The following is a description of a gene set: part of: HIV Life Cycle The late phase of the HIV-1 life cycle includes the regulated expression of the HIV gene products and the assembly of viral particles. HIV-1 gene expression is regulated by both cellular and viral proteins. Although the initial activation of the HIV-1 transcription is facilitated by cellular transcription factors including NF-kappa B, this activation results in the production of primarily short transcripts. Expression of high levels of the full length HIV-1 transcript requires the function of the HIV-1 Tat protein which promotes elongation of the HIV-1 transcript. The HIV-1 Rev protein is required post-transcriptionally for the expression of the late genes. Rev functions by promoting the nuclear export of unspliced and partially spliced transcripts that encode the major structural proteins Gag, Pol and Env, and the majority of the accessory proteins (Malim et al., 1989; reviewed in Pollard and Malim 1998. Reactome Pathway: Late Phase of HIV Life Cycle species: Homo sapiens, and this is the list of marker genes: GTF2E2, NUP98, AAAS, GTF2H4, XPO1, CHMP4A, vpr, POM121, UBC (ubiquitin C), UBA52, GTF2F2, TCEA1, CCNK, CHMP2B, UBAP1, TAF6, MVB12A, TAF15, vpu, POLR2J (NCBI Gene Id 5439), CHMP4C, RAE1, TAF10, POLR2A, VPS37B, RPS27A, ERCC3, TAF4B, TAF1L, ELOC, NUP42, NUP155, NUP214, GTF2E1, RNMT, VPS37D, ELOB, GTF2H1, VPS37A, NUP188, NELFCD (negative elongation factor complex member C/D), CDK9, NEDD4L, TAF1, CHMP7, ELOA2, RANBP2, GTF2A2, NCBP2, POLR2C, VPS37C, rev, NUP160, CHMP3, NUP210, TAF7, NUP50, MNAT1, POLR2H, GTF2B, GTF2H3, CTDP1, NUP58, ELOA, TBP, TAF4, NUP133, ERCC2, SEC13, NUP153, CHMP6 (charged multivesicular body protein 6), TAF7L (TATA-box binding protein associated factor 7 like), GTF2H5 (general transcription factor IIH subunit 5), PDCD6IP, NUP37, ELL, CCNT1, TPR, tat, NUP107, NUP54, NELFA, TAF2, POLR2K, SSRP1, env, VPS28, CHMP2A, NMT1, TAF11, CCNT2, GTF2F1, NUP43, gag, VPS4B, gag-pol, TAF9B, POLR2G, NMT2, nef, POM121C, NCBP1 (NCBI Gene Id 4686), UBB, POLR2E, POLR2D, VPS4A, NUP35, TAF13, NDC1, TAF8, TAF3, NELFE, POLR2L, NELFB, FURIN, NUP85 (NCBI Gene Id 83705), TAF9, CHMP5, PPIA, TAF12, TAF5, RANGAP1, SUPT4H1, NUP62, SEH1L, RNGTT, POLR2F, VTA1, GTF2H2, CCNH, TSG101, NUP205 (nucleoporin 205), RANBP1, POLR2I, RCC1, POLR2B, CHMP4B, MVB12B, GTF2A1, RAN, NUP88, SUPT5H, vif, SUPT16H, CDK7, NUP93